Given this list of marker genes SREK1, SLC8A3, NTM, STEAP1, RPL19, KCNJ5, SH3PXD2A, CAMKK1, SLC12A9, IL1RN, CHRNA3, FAM98A (NCBI Gene Id 25940), GABRQ, PNPLA6, CHMP1A, AKT2, SPI1, MAPK13, TWF1, PIP4K2A, KIFC3, CFAP298 (cilia and flagella associated protein 298), GNL3, ADRM1, NETO1, CASKIN2, ARFIP2, BARD1, PARP16, CTDNEP1, SYVN1, ATXN1, ZNF410, BCHE, RAD9A, COL4A1, VAPA, THPO, SHROOM3, WRAP53, IL21R, TMEM53, CBLN3, CSF3R, DDX52, FOXJ2, PLEKHO2, CD302, THAP4 (NCBI Gene Id 51078), VAMP1 (NCBI Gene Id 6843), TNFRSF19, SS18L2, TMEM14C, RABEP2, RDH16, KIRREL1, FHIT, MYOZ1, SPIRE2, SCG3, PEX11A (peroxisomal biogenesis factor 11 alpha), RESP18, ZNHIT2, GPR12, HSF1, MVD, AGFG2, KRI1, CDX4, TUBA3C (NCBI Gene Id 7278), CCT8, RCE1, FOS, TAX1BP1, NUDT3, SLC11A2, APBA3, CYBRD1, TSGA13, COL4A3, GUCY2C, HAAO, RSPRY1, SCYL1, PYCR2 (NCBI Gene Id 29920), DSP, OGFOD2, HEBP2, STYXL1, MYF6, ABCC10, SAMSN1, ADAM11, ING2, HAUS3, PDCD7, ARMC6, BRD4, OPRD1, SYNJ2, HR, PYCARD, ADAM9, POLDIP2, PIK3C2G, ANGPT2, NCAPH2 (NCBI Gene Id 96652), C2, MVP, SPHK1, UBALD1, SMAD1, F2, FLNC, LRP5, CLCNKB, MAP4K2, TCP11, ABCF1, CNOT9, OLFM1, THYN1, ZNF707, TCEA3, UBTD1, LIPG, RAD54L2, IST1, CPA2, MAFB, TMEM144, EXTL3, ADORA2B, NXT1, SLC38A5, ALPK3, BCL7B, RPP25L, CSNK1A1, HSPB7, DDIT4, PTPMT1, RPL23A, PGAP6, RTN4R, PADI1, MAD1L1, HTR1D, MAP3K11, SLC35F6, POC5, HILPDA, NELFB, TMC2, RPL35 (NCBI Gene Id 92393), VASN, PLBD1, SENP3, GJA1, G6PC2, MORF4L1, RGS17, RLN1, MRPS24, SOAT2, ATXN7L3, KLHL11, USP2, DOK1, DHX38, GFER, IER3, LTBR, C8orf82, PLS1, TNIP2, SLC41A1 (solute carrier family 41 member 1), SMPD4, APLP2, MC5R, VRK3, PLCE1, CCDC191, GUCD1, VAV1, MTERF4, TBC1D10A, PRL, COMMD7, HNF4A, TPO, CDC26, EEF1AKMT1, MOBP (NCBI Gene Id 4336), TBX3, MNS1, COQ8B, GFOD2 (Gfo/Idh/MocA-like oxidoreductase domain containing 2), S1PR4, TSC22D4, here is a description of the gene set: Human Gene Set: GSE23308_CTRL_VS_CORTICOSTERONE_TREATED_MACROPHAGE_UP Genes up-regulated in macrophages: untreated versus corticosterone. Inappropriate excess of the steroid hormone aldosterone, which is a mineralocorticoid receptor (MR) agonist, is associated with increased inflammation and risk of cardiovascular disease. MR antagonists are cardioprotective and antiinflammatory in vivo, and evidence suggests that they mediate these effects in part by aldosterone- independent mechanisms. We used affymetrix to characterize the effect of Mineralocorticoid Receptor deletion on macrophage transcriptional profile, and identify its requirement in normal glucocorticoid signalling. from publication Usher MG, Duan SZ, Ivaschenko CY, Frieler RA, Berger S, Schütz G, Lumeng CN, Mortensen RM (PMID 20697155) species: Homo sapiens